The following is a description of a gene set: Mouse Gene Set: GOBP_POSITIVE_REGULATION_OF_LEUKOCYTE_ADHESION_TO_VASCULAR_ENDOTHELIAL_CELL species: Mus musculus Any process that activates or increases the frequency, rate or extent of leukocyte adhesion to vascular endothelial cell., and this is the list of marker genes: Rhoa, Gcnt1, Itgb2, Alox5, Capn1, Rela, Irak1, Ccr2, Chst2, Il6, Fut7, Traf6, Fut4 (fucosyltransferase 4), Selp, Icam1, Ets1, Tnf, Gp1ba, Itga4, Nfat5, Mdk, Chst4, Elane, St3gal4, Pawr, Ptafr, Sele